Given this list of marker genes Bmp7, Gata3, Wt1, Bmp4, Flcn, Ifng, here is a description of the gene set: Mouse Gene Set: GOBP_NEGATIVE_REGULATION_OF_CELL_PROLIFERATION_INVOLVED_IN_KIDNEY_DEVELOPMENT Any process that stops, prevents or reduces the frequency, rate or extent of cell proliferation involved in kidney development. species: Mus musculus